The following is a description of a gene set: studied in species Homo sapiens Genes up-regulated in 33D1+ spleen dendritic cells: Flt3L Melanom injected mice versus healthy controls. Dendritic cells (DCs) process and present self and foreign antigens to induce tolerance or immunity. In vitro models suggest that induction of immunity is controlled by regulating the presentation of antigen, but little is known about how DCs control antigen presentation in vivo. To examine antigen processing and presentation in vivo we specifically targeted antigens to the two major subsets of DCs using chimeric monoclonal antibodies. Unlike CD8+ DCs that express the cell surface protein CD205, CD8- DCs, which are positive for the 33D1 antigen, are specialized for presentation on MHC class II. This difference in antigen processing is intrinsic to the DC subsets and associated with increased expression of proteins associated with MHC processing. from publication Dudziak D, Kamphorst AO, Heidkamp GF, Buchholz VR, Trumpfheller C, Yamazaki S, Cheong C, Liu K, Lee HW, Park CG, Steinman RM, Nussenzweig MC (PMID 17204652) Human Gene Set: GSE6259_FLT3L_INDUCED_VS_WT_SPLENIC_DC_33D1_POS_UP, and this is the list of marker genes: MDH1, STOM, RTRAF (RNA transcription, translation and transport factor), CASP1, PAH, PGS1, NFAM1, IQSEC1, SDE2 (SDE2 telomere maintenance homolog), RRAS, LRRC75A, HPGD, NFKBIZ, STX2, KIAA1217, SMAGP, ORAI3, NF2, RBPMS, SPG21, MBP, MRPL30, NCOA3, MMD, PYHIN1, MOB1B, NAPSA, CXCL13 (C-X-C motif chemokine ligand 13), CD72, TBC1D13, TMCC3, SLCO4A1, TBL1X, SNAP29, HLA-B, C5AR1, OSTM1, SHB (SH2 domain containing adaptor protein B), SPACA6, LMO3, AP1M1, CALM3, SLC6A6, ATXN7L3B, S100A13, KCNJ2, S100A4, STARD3, SLC2A6, IFIH1, PLXDC2, SLC38A2, TENT4A, MARCHF1, CMTM6, ZDHHC14, NEK10, AGMO, CCDC50, FBRSL1, TMEM176A, EBI3, PLCB4, DRAM1, NUP153, BORCS6 (NCBI Gene Id 55491), CIITA, RUBCNL, TRAF1, RNF24, PLA2G4A, SUSD6, SMIM14, TLR7, RILPL2, CD74, PEX16, TWF2, EGR2, BST1, PATZ1, GALNT10, PLEKHA2, CST3, CCR2, LIPE, OASL, IRF9, KCTD10, OLFM1, NUDT9, CRYBG1, USP18, TMEM209, GOLGA3, FPR1, SLC25A16, ALOX5, SERPINB8, FAM174A, TNIP1, ZDHHC7, SGPP1, HIPK2, LPIN2, CLEC10A, GPR107, CDK2AP1, NAAA, GSDMD, UBAC2, NDRG2, ABRAXAS2, ZC2HC1A, MED22, LY6S, C1orf21, CORO1A, TMEM38B, NUPR1, CNBP, PARP12, ANO10, PBX3, PGAP2, PPWD1 (NCBI Gene Id 23398), TBL1XR1, FXYD2, PNP, SERTAD2, RMND5B, AGPAT3, TTC28 (NCBI Gene Id 23331), PRCP (prolylcarboxypeptidase), GPR155, TNFSF10, SAMTOR, RAC2 (NCBI Gene Id 5880), TIFAB, CPNE2, FOLR2, CD302, MARVELD1, PSMD10, ORC5, RNASE6, SP100, SURF6, FGD3, SMAD3, BTG2, MRPL45, TASL, SUMO3, ST8SIA4, EPSTI1, C3orf70, DAXX, NCF1, PTPRO, STXBP1, DRG1, TMCO6, ATP10A, DCXR (dicarbonyl and L-xylulose reductase), SLC5A3, LDLRAD3, SURF2 (NCBI Gene Id 6835), TMEM176B, RBPJ, TLR4, B3GNT2, C1QA, NRP2, SIGLEC1, ZMYND8, PPIP5K2, CD14, CAPG